The following is a description of a gene set: part of: Mitotic G2-G2/M phases Reactome Pathway: G2/M Transition This event has been computationally inferred from an event that has been demonstrated in another species.<p>The inference is based on the homology mapping from PANTHER. Briefly, reactions for which all involved PhysicalEntities (in input, output and catalyst) have a mapped orthologue/paralogue (for complexes at least 75% of components must have a mapping) are inferred to the other species. electronically inferred by orthology from the curated human pathway species: Mus musculus, and this is the list of marker genes: Tubb4b, Gtse1, Psmc2, Psmd13, Nedd1, Prkar2b, Obi1, Wee1, Ccna1 (cyclin A1), Tubal3, Hmmr, Ppme1, Ywhae, Tuba1c, Psmc3, Nde1, Tuba1a, Rab8a, Cdc25c (cell division cycle 25C), Psma1, Psmc5, Haus8, Psmc4, Optn, Ticrr, Psma5, Hjurp, Cdk1, Cep41, Fbxl7, Psmd12 (NCBI Gene Id 66997), Lcmt1, Prkaca, Csnk1e, Ninl, Psma3, Cep152, Cep192, Ccnb1, Tubb4a, Haus5, Cul1, Cep57, Psmb6, Xpo1, Psma2, Fzr1 (NCBI Gene Id 56371), Tubgcp2, Cep131, Tubgcp3, Sdccag8, Tpx2, Cep290, Tuba3b, Bora, Cep63, Sfi1, Psmb5, Tuba8, Dctn1, Psmb7, Psmc6, Ppp2r1b, Tubb6, Tubb2b, Clasp1, Ppp2r2a, Cenpj, Psmd6, Cep43, Psma7, Tubgcp6, Mzt1, Rps27a, Psmd1, Psmd7, Fkbpl, Actr1a, Ubb (ubiquitin B), Dynll1, Cep72, Cdkn1a, Psma4, Tuba1b, Plk1, Cep135, Haus1, Haus7, Psmb4, Psmc1, Cdk11b, Ccnh, Tuba4a, Ajuba, Phlda1, Trp53, Psma6